The following is a description of a gene set: species: Mus musculus Mouse Gene Set: GOCC_EXTRINSIC_COMPONENT_OF_SYNAPTIC_VESICLE_MEMBRANE The component of the synaptic vesicle membrane consisting of gene products and protein complexes that are loosely bound to one of its surfaces, but not integrated into the hydrophobic region., and this is the list of marker genes: Doc2b, Syn2, Atr, Syn1, Atp6v1a, Atp6v1e1, Snap29, Sgta, Atp6v1b2, Atp6v1c1, Atp6v1g2, Atp6v1f, Cltc, Tprg1l, Rph3a, Atp6v1h, Amph, Btbd8, Atm, Atp6v1g1, Atp6v1b1, Syn3, Bin1, Doc2a, Atp6v1d